The following is a description of a gene set: Catalysis of the nonhydrolytic addition or removal of a carboxyl group to or from a compound. Human Gene Set: GOMF_CARBOXY_LYASE_ACTIVITY species: Homo sapiens, and this is the list of marker genes: PPCDC, HDC (NCBI Gene Id 3067), OAZ2, ODC1, GAD1, PCK2, PCK1, DDT, PISD, PARK7, GADL1, URAD, UMPS, UROD, FAHD1, AZIN2, UXS1, ECHDC1, OAZ3, GAD2, ACMSD, PDXDC1, ME1, PAICS, AMD1, PDXDC2P-NPIPB14P, OAZ1, ME3, BCKDHA, COQ4, ME2, ACOD1, DDC, AZIN1, MVD, CSAD, GOT1, MLYCD, GGCX